Given this list of marker genes LRRC36, NOVA2, ENSG00000223528, NRARP, FAM124A, RALYL, TMEM178A, ZNF521, ARHGEF26, IL33, DIPK2B, CDH5, KLF2, TMEM255B, CCM2L, CLEC1A, NOTCH4, AFF3, TIE1, LDB2, CARD10, LHX6, MEOX2, S1PR1, CACHD1, TEK, DLL4, APLNR, TCF15, FCGR2B, EXOC6, PLVAP, ARHGEF15, CYP1A1, ROBO4, TTLL10 (NCBI Gene Id 254173), VIPR1, CLEC4GP1, APLN, SOX18, LINC01681, ENSG00000260862, EGFL7, LOXHD1, CLEC14A, CD93, ENSG00000237070, CRHBP, KL, HS3ST3A1, FUT9, JCAD, DLEU1, PCSK5, SOX7, BCL6B, NDNF, TM4SF18, LINC02880, RASSF9, RAMP2, ADGRL4, FBXW10B, PKN3, HECW2, TMC7, SHANK3, IGSF9B, JAM3 (NCBI Gene Id 84887), CD34, CDH13, CALHM4, LINC01049, CYYR1, PCDH17, RHOJ, LRP6, BMS1P10, SHE, ADGRF5, NTS, NNAT, GRB14, PDE1C, ECSCR, RASIP1, KDR, RAMP2-AS1, ERG, THSD1, FCGR2C, SYN2, ST6GALNAC3, TAMALIN, CLDN5, RALGAPA2, FAM124B, ENSG00000233251, CGNL1, HACE1, USHBP1, SLC22A10, HEY1, here is a description of the gene set: Marker genes curated from the annotated cluster as represented in the Descartes Human Gene Expression During Development database. Human Gene Set: DESCARTES_FETAL_PLACENTA_VASCULAR_ENDOTHELIAL_CELLS from publication Cao J, O'Day DR, Pliner HA, Kingsley PD, Deng M, Daza RM, Zager MA, Aldinger KA, Blecher-Gonen R, Zhang F, Spielmann M, Palis J, Doherty D, Steemers FJ, Glass IA, Trapnell C, Shendure J (PMID 33184181) studied in species Homo sapiens The gene expression program underlying the specification of human cell types is of fundamental interest. The study authors generated human cell atlases of gene expression and chromatin accessibility in fetal tissues. For gene expression, the study authors applied three-level combinatorial indexing to >110 samples representing 15 organs, ultimately profiling ~4 million single cells. The study authors leveraged the literature and other atlases to identify and annotate hundreds of cell types and subtypes, both within and across tissues. Our analyses focused on organ-specific specializations of broadly distributed cell types (such as blood, endothelial, and epithelial), sites of fetal erythropoiesis (which notably included the adrenal gland), and integration with mouse developmental atlases (such as conserved specification of blood cells). These data represent a rich resource for the exploration of in vivo human gene expression in diverse tissues and cell types.